The following is a description of a gene set: species: Homo sapiens Human Gene Set: chr13q14, and this is the list of marker genes: RNY4P30, RPL27AP8, GUCY1B2, THSD1, COX17P1, RB1-DT, LINC00458, ZNF646P1, FOXO1, LINC00345, LINC01198, SUGT1, TPT1, SLC25A30, LINC02938, MIR3168, VWA8, RPL36P19, RNY1P6, RUBCNL, TUBBP2, RNY3P2, PCDH8P1, ENSG00000288598, MORF4L1P4, LINC01065, RNU6-65P (RNA, U6 small nuclear 65, pseudogene), SUCLA2-AS1, FKBP1AP3 (FKBP prolyl isomerase 1A pseudogene 3), RGCC, PRELID3BP2, TPTE2P2, DNAJC15, ATP5PBP1, ALG11, DHRS12, RNASEH2B, OR7E155P, WDFY2, SNRPGP11, MIR320D1, ENSG00000276527, LPAR6, LINC00462, CCDC122, PPP1R2P4, MIR3613, ENSG00000304062, DLEU7, MAPK6P3, LRCH1, TMEM272, KPNA3, RPL13AP25, CKAP2-DT (CKAP2 divergent transcript), LINC00562, RPS4XP16, NEK3, FAM216B (NCBI Gene Id 144809), DLEU2, RNU6-68P, RN7SL320P, MED4-AS1, ENOX1, MIR4305, UTP14C, CPB2, THSD1P1, HTR2A-AS1, KARS1P1, MIR759, SNORA31, POLR2KP2, SUGT1P3, LCP1, COG6, DLEU1, LINC00598, KBTBD6, FNDC3A, ABITRAMP1, HNRNPA1L2, FABP5P2, LINC01050, RN7SL515P, DGKH, EBPL, VWA8-AS1, RN7SL49P, RNU6-57P, PSME2P2, ZC3H13, LINC00332, NUFIP1, CBY2, CNMD, ELF1, PPIAP26, TNFSF11, GTF2F2, KBTBD7, RNA5SP27, ENSG00000297110, RN7SL597P, SPRYD7, NRAD1, KCNRG, ERICH6B, LINC01077, RNY4P24, RCBTB1, ESD, NAP1L4P3, TSC22D1, RN7SKP3, RN7SKP4 (RN7SK pseudogene 4), LACC1, FABP3P2, AKAP11, RPL34P26, DGKZP1, RPL17P51, SMARCE1P5, RNY3P9, FAM124A, RNA5SP28, RAD17P2, RNASEH2B-AS1, ATP7B, CYCSP34, VPS36, CDKN2AIPNLP3, CPB2-AS1, LINC01055, TUSC8 (tumor suppressor candidate 8), TPTE2P5, RNY4P14, RLIMP1, SUGT1-DT, CALM2P3, CAB39L, MLNR, CTAGE10P, OGFOD1P1, CCDC70, RN7SL618P, MRPS31P5, RNU6-60P, OR7E36P, PPIAP25, RNU2-6P, COX4I1P2, MIR8079, MIR15A, SUCLA2, SERPINE3, TIMM9P3, LINC00563 (long intergenic non-protein coding RNA 563), LINC00428, MRPS31, NAA16, RPL5P31, MIR4703, RPL18P10, MIR5693, MIR16-1, SLC25A15, C13orf42, LINC00558, MIR5006, RN7SL288P, SMIM2-AS1, CTAGE3P, HTR2A, WBP4, ENOX1-AS2, ST13P4, RNU6-74P, RN7SKP5, PPP1R26P1, LINC00390, RNA5SP29, CYSLTR2, SNORA31B, OR7E101P, SETDB2, TRIM13, AZU1P1, INTS6-AS1, ENSG00000212553, RNY4P9, LINC00400, GNG5P5, LINC02341, GPALPP1, COX7CP1 (COX7C pseudogene 1), OLFM4, RPS28P8 (ribosomal protein S28 pseudogene 8), INTS6, SLC25A30-AS1, RCN1P2, ENOX1-AS1, NEK5, TPT1-AS1, MTRF1, KCTD4 (NCBI Gene Id 386618), LHFPL6 (NCBI Gene Id 10186), NUDT15, MIR621, SNRPGP14, LINC00330, LINC02333, ENSG00000273523, ARL11, RB1, CHCHD2P11, PHF11, TSC22D1-AS1, AKR1B1P4, RN7SKP2 (NCBI Gene Id 100873846), CKAP2, MED4, MRPS31P4, RN7SL413P, MIR1297, EPSTI1, ZDHHC4P1, TPTE2P3, OR7E37P (NCBI Gene Id 100506759), LRRC63, RCBTB2, KBTBD6-DT, PCNPP5 (PEST containing nuclear protein pseudogene 5), ITM2B, COG3, RN7SL700P, SERP2, SIAH3, CDADC1, RGS17P1, ENSG00000290704, FHP1, PCDH8, RAC1P3